The following is a description of a gene set: studied in species Mus musculus Any process that modulates the frequency, rate or extent of T-helper 17 cell differentiation. Mouse Gene Set: GOBP_REGULATION_OF_T_HELPER_17_CELL_DIFFERENTIATION, and this is the list of marker genes: Ep300, Nfkbiz, Zbtb7b, Ascl2, Rc3h2, Rc3h1, Smad7, Opa1, Brd4, Il4, Malt1, Brd2, Mir326, Il2, Ccl20, Tnfsf18, Foxp3, Nfkbid, Loxl3, Il23a, Tbx21, Cd69, Lgals1, Mir301, Zc3h12a, Nlrp3, Pf4, Ccr6